Given this list of marker genes RPS19, MDM2, SOX6, PRKAR1A, LMNA, ATM (NCBI Gene Id 8068), RPL11, RPS28, POLD1, COL11A2, POLE, FGFR3, MSH2, RPL31, TRPS1, TREX1, ADA2, RNASEH2B, MSX2, CDKN2A, POLR1C, PIK3CA, SHOX, RPL18, SEMA4A, FGFR1 (NCBI Gene Id 84151), RPS10, RB1, RPS17 (NCBI Gene Id 6218), MLH1, RPL27, PTEN, IFNG (interferon gamma), PTH1R, RPL26 (NCBI Gene Id 6154), PHF21A, IDH1, POLR1B, RPS20, RAD21, PORCN, KRAS, MSH6, CHD6, AAGAB, SQSTM1, IPO8, ANAPC1, GATA1, APC, RPL35A, CHEK2, MAD1L1, PTPN11, RPL5, RPS7, RPL9, MUTYH, ACP5, POLR1D, CHRNG, HEATR3, RNASEH2C, RPS29, MTAP, RNU7-1, IFIH1, TAF15, RECQL4, AKT1, PDE11A, RPL15, EPCAM, ATP7A, TCOF1, EXT2, TSR2, RPL8, ADAR, RPS24, ACVR1, NFATC2, TGFBR2, TSC1, GLI3, RPS15A, COL2A1, LSM11, SAMHD1, RPS27, WRN, PMS1, ALX4, RPS26, EXT1, RNASEH2A, ACAN, TSC2, NR4A3, BRCA2, PMS2, BMPR1A, TP53, COL14A1, RPL35, IDH2, here is a description of the gene set: species: Homo sapiens Neoplasm of the skeletal system A tumor (abnormal growth of tissue) of the skeleton. Human Gene Set: HP_NEOPLASM_OF_THE_SKELETAL_SYSTEM